The following is a description of a gene set: Any apoptotic process in an epithelial cell. species: Homo sapiens Human Gene Set: GOBP_EPITHELIAL_CELL_APOPTOTIC_PROCESS, and this is the list of marker genes: MIR4516, CAPN10, PIAS4, USP17L24, SERPINB13, PDX1, MDK, RYR2, TCF7L2, TMEM258, HDAC3, CFLAR (CASP8 and FADD like apoptosis regulator), PRKAA2, BOK, ISL1, HAND2, EIF2S1, KRT8, GSN, BCL2L1, USP17L6P, UMODL1, STK3, BCL2, SAV1, CASP6, EDNRA, PIK3CG, BID, SRSF6, YAP1, ADAR, NEUROD1, STK4, RB1, LEF1, CASP3, ATOH1, SIX3, PRKAA1, MTCH2, PPARA, DNMT3A, JAG2, PKHD1, CAST, JAK2, E2F1, PLA2G1B, NFKBIZ, SFRP4, MIR182, NUPR1, ANXA2, E2F2, MIR675, ARF6, PLA2R1, TIA1, FGF4, ATF2, USP53, NKX2-6, IL6, BTC, TGFBR2, BAX, ITGB3BP, TMF1, CASP9, CARM1 (coactivator associated arginine methyltransferase 1, NCBI Gene Id 10498), EXOC5, NPC1, ABL1, ESR1 (estrogen receptor 1, NCBI Gene Id 2099), WFS1, NKX2-5, ZFP36L1, CDKN1B, WNT11, KRT18, ZFP36, HMOX1